The following is a description of a gene set: studied in species Homo sapiens Downstream signaling of activated FGFR1 Human Gene Set: REACTOME_DOWNSTREAM_SIGNALING_OF_ACTIVATED_FGFR1, and this is the list of marker genes: FGFR1, FRS3, SHC1, HRAS, FGF8, FGF23, FGF4, FGF20, PLCG1, FRS2, PIK3R1, FGF22, FGF17, NRAS, KRAS, FGF2, GRB2, FGF10, FLRT3, FGF3, GAB1, PIK3CA, FGF5, PTPN11, FGF9, FGF6, FGF1, KL, SOS1, FLRT2, FLRT1